The following is a description of a gene set: The initial attachment of a membrane or protein to a target membrane. Docking requires only that the proteins come close enough to interact and adhere. studied in species Mus musculus Mouse Gene Set: GOBP_MEMBRANE_DOCKING, and this is the list of marker genes: Vamp2, Atp2a2, Ykt6, Exoc3, Pacs2, Syt1, Stx4a, Stx1a, Rab8a, Gramd2a, Syde1, Stx12, Stx1b, Plek, Exoc4, Vapb, Snap29, Rims3, Icam1, Stx16, Psen2, Stx2, Stx5a, Uso1, Esyt2, Rock1, Ezr, Pex16, Ralb (v-ral simian leukemia viral oncogene B), Stx6, Stx8, Stxbp2, Exoc5, Atg14, Vmp1, Cep290, Rims2, Calm2, Esyt1, Bves, Camk2a, Stx19, Stx11, Exoc7, Cftr, Kcnb1, Stx3, Ctbp2, Tprg1l, Unc13b, Pdzd8, Vps11 (NCBI Gene Id 71732), Esyt3, Gnao1, Exoc6, Exoc8, Vapa, Unc13a, Unc13c, Calm1, Snx3, Rims1, Stx7 (NCBI Gene Id 53331), Vps18, Stx17, Cav2, Ndrg4, Cep83, Septin5, Pex26, Exoc2, Selenon, Cln3, Exoc6b, Msn, Calm3 (NCBI Gene Id 97428), Rab7, Ppfia3, Chp1, Bloc1s6, Sytl2, Ahcyl1, Stxbp3, Exoc1, Ncam1, Stxbp1